The following is a description of a gene set: The gene expression program underlying the specification of human cell types is of fundamental interest. The study authors generated human cell atlases of gene expression and chromatin accessibility in fetal tissues. For gene expression, the study authors applied three-level combinatorial indexing to >110 samples representing 15 organs, ultimately profiling ~4 million single cells. The study authors leveraged the literature and other atlases to identify and annotate hundreds of cell types and subtypes, both within and across tissues. Our analyses focused on organ-specific specializations of broadly distributed cell types (such as blood, endothelial, and epithelial), sites of fetal erythropoiesis (which notably included the adrenal gland), and integration with mouse developmental atlases (such as conserved specification of blood cells). These data represent a rich resource for the exploration of in vivo human gene expression in diverse tissues and cell types. Human Gene Set: DESCARTES_FETAL_CEREBELLUM_MICROGLIA Marker genes curated from the annotated cluster as represented in the Descartes Human Gene Expression During Development database. from publication Cao J, O'Day DR, Pliner HA, Kingsley PD, Deng M, Daza RM, Zager MA, Aldinger KA, Blecher-Gonen R, Zhang F, Spielmann M, Palis J, Doherty D, Steemers FJ, Glass IA, Trapnell C, Shendure J (PMID 33184181) species: Homo sapiens, and this is the list of marker genes: FERMT3, RPS10-NUDT3, H2BP2, NLRP3, LPAR5, ALOX5AP, C11orf21, NINJ1, CAST, CHIT1, SLAMF6, LYZ (NCBI Gene Id 4069), MR1, IL6, CARD9, PDCD1LG2, FMN1, CTSC, MYO7A, RAB39A, AIF1, MYO1F, VAV1, DEF6, CEACAM21, GP9, GPR84, ENSG00000249631, GASK1B-AS1 (NCBI Gene Id 285505), HAVCR1, CD300LF, PLD1, SMIM35, TSPAN32, CRHBP, NPL, IFNGR1, ADRB2, TMEM86A, RHOH, MKNK1, CXCL8, HAVCR2, UAP1L1, RAB20, PTPN7, SIGLEC11, PDE4DIPP7, ITGB2-AS1, ANXA4, HMGA1P4, CX3CR1, ARHGAP4, LINC01645, BATF3, IPCEF1, TLR5, LAG3, TYMP, BCL2A1, ARL11, OTUD1, PIK3R5, LINC00996, KCNJ5-AS1, HLA-DMB, PARP15, SIGLEC8, GOLGA8H, ANKH, LYN, IL12RB1, HSPA6, HLA-DMA, CTSS, GGTA1, LRRC18, LILRA6, GM2A, BLVRB, NFAM1, NCF4, C19orf38, CTSB (NCBI Gene Id 3896), TBXAS1, SPN, JAK3, CFD, SUCNR1 (NCBI Gene Id 56670), LILRA1, IRAK2, ULK4P1, CIMAP1B, LILRB2, BMP2K, CNGA1, P2RY8, MIR222HG (miR222/221 cluster host gene), GALNT6 (polypeptide N-acetylgalactosaminyltransferase 6), ICAM1, GAB2, CCDC88B, IL17RA, RASAL3, LINC01235, DPRXP4, GAA, PTAFR, ENSG00000231204, TMCO4, CYSLTR1, C1QA, SLC7A7, HMGB1P21 (high mobility group box 1 pseudogene 21), PTGER4, TBC1D12, LRRC37A15P, CCR1, C5AR2, CASP5, COX6CP17, LINC01546, LILRB5, STXBP2 (NCBI Gene Id 6813), CD163, S100A9, S100Z, HMOX1, FAM157A, ADAMTS17, ERMAP, ZMYND15, ATG7, TLR2, RPS23P6, ITGAL, LNCAROD, CD68, ARRDC5, TNFRSF10C, MILR1, MERTK, TYROBP, PIK3CD, CAPG, ALDH3B1, PLCB2, LAPTM5, FBXO40, STYXL2, NFATC2, TEP1, LINC01845, OSCAR, C1QB, RGS10, SLC29A3, NCK1-DT, PLCG2, CLEC7A, LCP2, ABCC13, SPI1, CLEC19A, P3H2 (NCBI Gene Id 55214), CAPZB, NMRK1, ALOX5, GNA15, IL18, CXCL16, LINC01736, MEFV, LRRC74A, TXK, HCK, EEIG2, CD180, CD4, ICAM4-AS1, DPP4, PRKCD, KCNJ5, SALL1, HK2, IL10RA, ABCC5-AS1, SGK3, STEAP1B, FAM177B, KPNA2P3, SLC17A9, TMC8, PDK4, MIR142HG, RN7SL834P, RXFP1, SLC28A1, PTCRA, MAP3K5, DENND2D, BHLHE41, S100A4 (S100 calcium binding protein A4), GAPLINC, MEP1A, C1QC, ADAM28, DHRS9, HSD17B14 (NCBI Gene Id 51171), RN7SL138P, C5AR1, ALOX15B, CDCP1, NFATC1, RCN3, TNFSF8, CLEC9A, LY86, SPP1, AMPD3, SLC22A18, LRRC25, RUNX1, PIK3AP1, S100A1, ADPGK (NCBI Gene Id 83440), PDK4-AS1, RNU4-53P, OLR1, CCR3, RAB3IL1 (RAB3A interacting protein like 1), CD37, MYOZ2, TMEM144, LINC01909, RPS29P20, FFAR2, CPA6, DAPP1, BTK, CD14, ADA2, APBB1IP, SLFN11, NFKBIZ, PLD4, COL8A2, BATF, EBI3, TREML1, WAS, ITGAM, BTG2, PLXDC2, CD53, SPATC1, RASL10A, RPH3AL-AS1, APOC1P1, KCTD9P1, RN7SL297P, LY96, ACY3, ENSG00000233569, LY86-AS1, SIGLEC5, SASH3, RBM47, CD274, TXLNB, STEAP1B-AS1, LINC00278, IL6R, LIMASI, ADAM9, C2, LILRA4, ANXA2R-AS1, CDKN1A, LY75, SLC15A3, LINC01684, ARL4AP5 (ADP ribosylation factor like GTPase 4A pseudogene 5), CFB, NPM1P10, TMEM156, FCGR2A, GPRC5D-AS1, AIDAP2, RABEP1, LINC02435, KIR3DX1, ARRDC2, IL1B, PRAM1, RNU7-29P, PLEKHA2, ITGB3, LINC02541 (NCBI Gene Id 101927686), CTSL (cathepsin L), H2BC18, LINC02985, SAMSN1, MAF, ATP6V1B2, SNX29, RERE-AS1, TNFSF18, CSF1R (colony stimulating factor 1 receptor), PDYN-AS1, GLDN, SLC37A2, PAQR5-DT, ATP8B4, TFEC, MFSD1, DOCK4, LINC01375, RHBDF2, ARHGAP12, AZIN2, WDFY4, CSF2RB, RTTN, ENSG00000254288, MANBA, TNFSF13B, GPR34, SORL1, TNFSF14, FCGR2B, LST1, SPTLC3, RNASET2, PYCARD-AS1, SP140, PARVG, SOCS6, TMEM273, ZNF710, GYPC, IGSF6, B3GNT5, SNAI3, RUBCNL, TLR1, LGMN, LINC00539, FMNL1, CORO1A, GBGT1, CSF3R, PIK3CG, SLC11A1, GBP2, WDR91, TEC, BIN1, CPVL, MMRN1, SLC5A9, IL1A, ARID5A, APOC4 (NCBI Gene Id 346), HRH1, DIAPH2-AS1, IGF1, CSF2RA, DUSP29, SMAP2, ABCC4, RIN3, PLA2G15, SLC25A24P1, ARHGAP27P1-BPTFP1-KPNA2P3, EGR2, DAGLB, RNY4P34, CD28, LILRB1, PTER, IGFLR1, MAP3K8, ZNF503-AS1, SIGLEC10, LRMDA, LINC02953 (long intergenic non-protein coding RNA 2953), NLRP4, LYVE1, FGL1, DOCK8, RGS1, CEP295NL, RNASE6, ACP3, RGL3, CD226, TRIM22, BIN2, NLRC4, MEPE, PLVAP, C3AR1 (NCBI Gene Id 719), FYB1, EDNRB-AS1, DOK3, GAB3, MNDA, GPBAR1, TM6SF1, SIGLEC14, RNU6-1228P, FOLR2, ADAMTSL4-AS2, ENSG00000253557, FGD2, H2BC11, CD36, SCIMP, CARD14, ARRB2, ENSG00000258168, ENSG00000232884, HCLS1, ABR-AS1, CD83, PLCL2-AS1, LINC02381, CASS4, CARD11, CLECL1P, CEBPA, RENBP, UNC13D, TLR6, SCIN, GAL3ST4, GLIPR1, SNX20, SULT1C5P, FAM149A, LINC02978, IL10, EVI2B, RN7SL172P, MAFB, ELL2, IL1RN, NABP1, ENSG00000254951, APOC1, SFMBT2, RNU2-59P, LRRK1, NFKBID, CRYBB1, FTL, MS4A14, MIR570, P2RY12, LINC02712, WASHC5-AS1, C3, RPL6P8, LINC01504, MITF, ERP27, SERPINA1, TAL1, SELL, AGMAT (NCBI Gene Id 79814), ADGRE4P, DNASE2, OSM, EGR3, CD300C, TMIGD3 (NCBI Gene Id 57413), LILRA2, SLC9A9, CTSZ, CD86, RASGRP4, TRAF3IP3, APOBR (NCBI Gene Id 55911), PCED1B-AS1, MROCKI, FCGR1BP, CCDC200, ASTL, SERPINF1, ARL5C, LAIR1, SIGLEC9, DIAPH2, MS4A7, OSBPL11, IRAG2, IRF8, PPP1R2P4, TMEM119, MPEG1, CCL2, HPSE, CD5L, ENTPD1, AP1B1, TMIGD2, IKZF1, TEX14, GPR132 (G protein-coupled receptor 132), STAT5A, HOMER3-AS1 (NCBI Gene Id 102724360), UNC93B1, HLA-F-AS1, SYK, APOE, RN7SL32P, MAN2B1, TBC1D22A, LOXL2-AS1, MAST3, LACC1, ARHGAP9, GPR183, TNFAIP8L2, AOAH, BNC2, SPNS3, CD33, CD84, SKAP2, ELF4, SLC16A6P1, LINC01194, GNB4, ENSG00000249738, PLEK, TREM2, PLA2G7, SLC2A5, VSIG4, SDS, CACNA2D4, BIRC7, TRPM2, CDKN2A, CYTH4, ST14, ACSM5, MS4A4A, HPGDS, ZC3H12D, XACT, TAGAP, LILRB3, NCKAP1L, LINC01768, RNU4-62P, EPHA1-AS1, RNFT1-DT (NCBI Gene Id 101927755), LINC03070, CD74, TMEM52B, SELPLG (selectin P ligand), LINC01094, B4GALT1, CD69, NRROS, TLR10, KBTBD12, CHI3L1, CYBB, ENSG00000237429, RAC2, TLR7, TLR4, TMEM106A, ARHGAP25 (Rho GTPase activating protein 25), LINC01678 (long intergenic non-protein coding RNA 1678), LINC02642, CASP1, IRF5, PLBD1, FPR1, UCP2 (uncoupling protein 2), CYTIP, FCER1G, TASL, IL7R, MACORIS, IL6R-AS1, PPARG, LINC00671, TANGO2, MRO, ITGB2, TFCP2L1, BLNK (NCBI Gene Id 29760), PTGS1, KCNK6, DOCK2, SUSD3, H2BC4 (NCBI Gene Id 8347), MX2, LCP1, P2RY13, GDPD4, RN7SL105P, DOCK8-AS2, P2RY6, ALPK1, CEP250-AS1, ADAP2, PCK2, LINC-PINT, LINC01480, SH3BP1, FCGR3A, ZEB2-AS1, GADD45B, LINC01141 (NCBI Gene Id 339505), ARHGAP15 (Rho GTPase activating protein 15), RYR1, RGS18, GPNMB, LILRB4, CH25H, FCGR1A, TNF, ITGAX, PTPN6, SLC38A4, MS4A6A, IL4I1, LRRC39, LPCAT2, SMPDL3A, LGALS3, HTRA1, CSF1, SIGLEC7, CREG1, FCGR2C, ARHGAP30, VWA7, P2RX1, DPP7, ADTRP, KCNK13, MTND5P2, DENND1C, FAM238A, PTPRC